The following is a description of a gene set: from publication Schaefer CF, Anthony K, Krupa S, Buchoff J, Day M, Hannay T, Buetow KH (PMID 18832364) Presenilin action in Notch and Wnt signaling studied in species Homo sapiens Human Gene Set: PID_PS1_PATHWAY, and this is the list of marker genes: PPARD, FRAT1, TAB1, HNF1A, CCND1, SSPOP, DVL1, MYC, NKD1, LRP6, CTNNB1, PSEN1, WIF1, GSK3B, NEDD4, APH1A, AXIN1, APH1B (NCBI Gene Id 83464), HDAC1, CTBP1, APC, ADAM10, WNT1, NOTCH1, DLL1, NLK, DTX1 (NCBI Gene Id 1840), MAP3K7, RBPJ, TLE1, NCSTN, MAPK3, PSENEN, PPP2R5D, TLE5, MAPK1, CSNK2A1 (casein kinase 2 alpha 1), FOS, CREBBP, JUN, DKK2, CSNK1A1, DKK1, KREMEN2, FZD1, FBXW11